Given this list of marker genes Csnk2b, Fundc1, Map1lc3b, Ulk1, Atg12, Pgam5, here is a description of the gene set: Reactome Pathway: Receptor Mediated Mitophagy This event has been computationally inferred from an event that has been demonstrated in another species.<p>The inference is based on the homology mapping from PANTHER. Briefly, reactions for which all involved PhysicalEntities (in input, output and catalyst) have a mapped orthologue/paralogue (for complexes at least 75% of components must have a mapping) are inferred to the other species. studied in species Mus musculus part of: Mitophagy electronically inferred by orthology from the curated human pathway